Given this list of marker genes RAB2A, MNAT1, PRPS2, DYNC2LI1, JPT2, SMAD1, RAP2A, RSPH9, NFKBIZ, SERPINE2, CNTRL, OIP5, RAB27A, CD300LF, FGD2, TBC1D9, SLIRP, DPYSL2 (NCBI Gene Id 1808), SPC24, NEK2, CAPZA1, ENTREP3, GPR183, KANSL1L, ESPL1, NDUFC2, HASPIN, IQGAP3, PAPSS1, RBM43, CENPH, ADI1, SGO1, TERF1, KIF22 (NCBI Gene Id 728037), PDLIM2, DHX35 (DEAH-box helicase 35), SLC12A2, CEP85, MCCC2 (methylcrotonyl-CoA carboxylase subunit 2), RDH11, TMEM242, BPHL, G2E3, PHYKPL, CENPU, EEFSEC, NPY, RAB31, VRK1, CDK14, LMNB1, TWF1, HSP90B1, PCIF1, CDCA2, CENPE, FNIP2, KNSTRN, TMEM273, C15orf61, WASF2, ATP8B4, RAB42, MRPL48, YDJC, DIP2A, SKA1, ZFAND4, LRIF1 (NCBI Gene Id 55791), CEP295 (NCBI Gene Id 85459), COA3, PDZK1IP1, ME1, NFE2L2, IDI1, ZNF764, PRR11, SLC16A6, AURKA, CPT1C (carnitine palmitoyltransferase 1C), PRC1, NEDD8, LY6H, EPB41L3, NOA1, AFP (alpha fetoprotein), GEMIN2, CHRAC1, NF2, NFXL1, PXK, RNF19A, HNRNPA1, DIPK2A, SGCB, SHC4, EI24, UBN1, EBPL, ATL1, EDNRB, COPZ2, SORBS3, HYLS1, FAM234B, LRRK2 (NCBI Gene Id 399472), ALS2CL, NKIRAS2, SKA2, NELFA, INTS13, MRPS33, CIP2A, RP9, CEP192, HAUS1, SPC25, CCND3, SYT11 (NCBI Gene Id 92303), PIMREG, KIF16B, STIL, NUDT21 (NCBI Gene Id 11051), TTC38, ZC3H4, KATNB1, XKR5, CYBB, EYA1, DICER1, EIF5A2, KREMEN1, SMIM12, TMEM263, FAM83H, SH3BP5L, FCHO1, IL18, IQCB1, ACD, RHOBTB1, P2RY12, NAT8L, CC2D1B, POT1, TNS1, SLC38A10, NIPAL3, FILIP1L, CENPT, TPX2, OSBPL1A, C8orf58, CENPO, BUB1B, GEN1, PRIM1, RAD51B, DNAJC30, RRAGD, BORCS7, RND2, CEP55, ABHD14B, TKT, TRIP6, OSCP1, CCNG1, CCDC91, H2AX, SVIP, CENPQ, ARPC2 (actin related protein 2/3 complex subunit 2), PFKM, PIR, HK1, PABIR2, EVI2B, FAM111A, EFCAB11, CYSLTR1 (NCBI Gene Id 10800), RAD51AP1, RBM3, UBE2T, METAP1D, MBLAC1, ITGAL, SYCE2, GPR176, PIGQ, CERS5, SUCLG2, S1PR1, CCN1, CASP3, VAMP3, SKA3, GTF2H2, RCSD1, here is a description of the gene set: from publication El Kasmi KC, Holst J, Coffre M, Mielke L, de Pauw A, Lhocine N, Smith AM, Rutschman R, Kaushal D, Shen Y, Suda T, Donnelly RP, Myers MG Jr, Alexander W, Vignali DA, Watowich SS, Ernst M, Hilton DJ, Murray PJ (PMID 17114459) IL-10 or IL-6 stimulation of control 129xC57BL/6 murine bone marrow derived macrophages in the presence of LPS. We used microarrays to detail the global programme of gene expression changes in response to IL-6 or IL-10 stimulation in the presence of lipopolysaccharide. BMDMs were isolated from control, IL-6-/-, and IL-10-/- mice on a 129XBL/6 mixed background mice and differentiated in the presence of CSF-1 for 6-7 days. Cells were scraped and plated in 6 well plates at 2x10e6/well. Cells were washed with complete DMEM and rested for 1-2 hr before stimulation with combinations of IL-10 (10 ng/ml), IL-6 (2 ng/ml) or LPS (100 ng/ml) for 45 min or 180 mins. Complete biological replicates were performed. Genes up-regulated in bone marrow-derived macrophages at 45 min of stimulation by LPS: wildtype versus IL10. species: Homo sapiens Human Gene Set: GSE5589_WT_VS_IL10_KO_LPS_STIM_MACROPHAGE_45MIN_UP